Given this list of marker genes INTS11, PTGIS, NUDT22, ZNF266, CRYZL1, NEUROD6, EVI2B, IGLJ3, COA8, CACNG4 (NCBI Gene Id 84745), NUP107, PLEKHA1, WWC3, AP2A1, PLAGL1, RGS5, AHNAK, MGA, ZNF185, IGHM, here is a description of the gene set: studied in species Homo sapiens Human Gene Set: MODULE_240 Genes in the cancer module 240.